The following is a description of a gene set: Genes down-regulated in comparison of peripheral blood mononuclear cells (PBMC) from patients with type 1 diabetes at the time of the diagnosis versus those at 1 month later. species: Homo sapiens from publication Kaizer EC, Glaser CL, Chaussabel D, Banchereau J, Pascual V, White PC (PMID 17595242) Objective: We hypothesized that type 1 diabetes (T1D) is accompanied by changes in gene expression in peripheral blood mononuclear cells (PBMCs) due to dysregulation of adaptive and innate immunity, counterregulatory responses to immune dysregulation, insulin deficiency and hyperglycemia. Research Design and Methods: Microarray analysis was performed on PBMCs from 43 patients with newly diagnosed T1D, 12 patients with newly diagnosed type 2 diabetes (T2D) and 24 healthy controls. One and four month follow-up samples were obtained from 20 of the T1D patients. Results: Microarray analysis identified genes differing in expression between newlydiagnosed T1D patients and controls at a false discovery rate of 0.05. Changes in expression of interleukin-1β (IL1B), early growth response gene 3 (EGR3), and prostaglandin-endoperoxide synthase 2 (PTGS2) resolved within four months of insulin therapy and were also observed in T2D suggesting that they resulted from hyperglycemia. With use of a knowledge base, 81/genes could be placed within a network of interrelated genes with predicted functions including apoptosis and cell proliferation. IL1B and the MYC oncogene were the most highly-connected genes in the network. IL1B was highly overexpressed in both T1D and T2D, whereas MYC was dysregulated only in T1D. Conclusion: T1D and T2D likely share a final common pathway for beta cell dysfunction that includes secretion of interleukin-1β and prostaglandins by immune effector cells, exacerbating existing beta cell dysfunction, and causing further hyperglycemia. The results identify several targets for disease-modifying therapy of diabetes and potential biomarkers for monitoring treatment efficacy. Human Gene Set: GSE9006_TYPE_1_DIABETES_AT_DX_VS_1MONTH_POST_DX_PBMC_DN, and this is the list of marker genes: RPGR, C2orf68, TNPO3, SLC66A1, ARMCX4, PNPLA2, RPL12, IGBP1, C1orf54, PDE6C, GLRA3, MYL9, TIMM9, HSPA1L, TGFB3, H2BC13, DNAJC1, YIPF6, USP13, LPP (NCBI Gene Id 4026), GMFG, PHF11, RHOBTB1, ATXN3L, RALGPS1, EPS15L1, PNPLA4, ADAMTS5, ATP2B4, SELP, TIMM8B, APOO, SLC4A5, TUG1, SLC14A2, POLH, SLC35E2B, FIG4, CDKN2C, BRD3, COA4, COMMD3, CLOCK, COX4I1, TTC1, IFT46, CASR, PRRG4, KRT4, RGS5, SLC25A14, PDPK1 (NCBI Gene Id 5170), F2, NOD1, GUCY1A1, ING4, STEEP1, RPL15, SLC38A7, SEMA6C, ESRP2, GUCY1B1, RBMS1, IER3IP1, NRCAM, ALLC, ANXA2P2, RPS15A, RUFY3, LUM, TNPO2, ADGRA2, SEMA6A, SCNM1, ZNF629, C8orf44, RTRAF, H4C3, DNAJC28, SOX13, RO60, KCNMA1 (NCBI Gene Id 3778), ATAT1, CLCA1, CCNT1, RBMX2, PCSK2, SLC12A5, ATP5F1C, DST, DUSP3, GPR143, ARMH3, RPL7A, TMEM254, CLEC1A, RABEPK, TRADD, PIPOX, NOP2, ZBTB40, BACE1, GRIA1, HTR1D, MAP3K19, ABCC10 (NCBI Gene Id 89845), KCNN3, CD1C, C3orf18, EIF5, ANKRD26, CCNF, HOXA9, SLITRK5, TNFSF18, GFOD2, ZNF609, RUFY2, MPV17, MC2R, DCTN2, ABITRAM, CBFA2T2, COQ6, LAMTOR5, MCCC1, C11orf16, SMAD1, TTF1, S100A10, MYL10, HSPB7, VCL, SLC18A1 (NCBI Gene Id 6570), TPCN1, TRIM62, TMEM104, CCDC71, PTCRA (pre T cell antigen receptor alpha, NCBI Gene Id 89959), SUGP2, RNF113A, KCNMB1, FABP1, POU3F1, DPM3, CCNI, AKR1C4, TIMM8A, GTF2H2B, CCSER2, TCF15, CCDC51, DAB2, SERF2, TMEM223, MTHFD2L, SUOX, RCAN2 (NCBI Gene Id 221402), LIPE, WT1-AS, MDH1, EIF5B, EIF2S2, ITGB5, TFG (NCBI Gene Id 50989), PAFAH1B2, COPG2IT1, METTL9, TULP3, BBC3, RPL14, GSTO1, RPL19, TRIM2, GFER, PBLD, PFDN5, GPR171, OXA1L, MIR622, OSBPL1A, TCTN1, ZRSR2P1, KLF7, BMPR1B, PRELID3A, ANXA2, DARS2, CP, HINT1, LRRC75B, TM6SF2 (NCBI Gene Id 53345), FAM111A, EBLN2, MAPKAPK5-AS1, SFSWAP, ASRGL1